Given this list of marker genes Iqsec3, Glra4, Kcnc4, Glra1, Glra3, Gphn, Glrb, Hspa8, Itgb3, Slc6a5, Eif2b2, Nlgn4l, Nlgn2, Arhgef9, Glra2, Nppa, Chrna7, Itgb1, here is a description of the gene set: A synapse that uses glycine as a neurotransmitter. studied in species Mus musculus Mouse Gene Set: GOCC_GLYCINERGIC_SYNAPSE